The following is a description of a gene set: Any process that activates or increases the frequency, rate or extent of isotype switching. Human Gene Set: GOBP_POSITIVE_REGULATION_OF_ISOTYPE_SWITCHING studied in species Homo sapiens, and this is the list of marker genes: HMCES, TGFB1, TP53BP1, KMT5C, PAXIP1, SHLD1, SHLD3, STAT6, ATAD5, EXOSC6, IL2, TNFSF13, PMS2, CLCF1, TBX21, SHLD2, EXOSC3, IL4, MAD2L2, TNFSF4, PTPRC (protein tyrosine phosphatase receptor type C), MSH2, RIF1, CD40, MLH1, TFRC, CD28, NSD2, KMT5B